The following is a description of a gene set: studied in species Homo sapiens Human Gene Set: GOBP_PROSTATE_GLAND_GROWTH The increase in size or mass of the prostate gland where the increase in size or mass has the specific outcome of the progression of the gland, from its formation to its mature state., and this is the list of marker genes: PSAP, SOX9 (SRY-box transcription factor 9), FGFR2, PLAG1, CYP19A1, PRLR, ESR1, AR, PSAPL1, IGF1, SHH, UBE3A